The following is a description of a gene set: Mouse Gene Set: KUMAR_TARGETS_OF_MLL_AF9_FUSION studied in species Mus musculus Myeloid leukemia model in mice with germ-line MLL-AF9 fusion knock-in: genes changed in comparison among the leukemic, preleukemic and wild-type animals. Identification of the targets of mixed lineage leukemia (MLL) fusion genes will assist in understanding the biology of MLL fusion gene leukemias and in development of better therapies. Numerous studies have implicated HOXA9 as one of the possible targets of MLL fusion proteins. To determine if HOXA9 was required for leukemia development by MLL fusion genes, we compared the effects of the Mll-AF9 knock-in mutation in mice in the presence or absence of Hoxa9. Both groups of mice showed myeloid expansion at 8 weeks and then developed myeloid leukemia with a similar incidence and time course. The leukemia in the mice lacking Hoxa9 generally displayed a more immature myeloid phenotype than that in the mice that were wild-type for Hoxa9. Gene expression profiling revealed that expression of Mll-AF9 led to overexpression of Hoxa5, Hoxa6, Hoxa7, Hoxa9, and Hoxa10. Thus, genes of the Hox-a cluster are important in defining the phenotype but not the incidence of Mll-AF9 leukemia. These results demonstrate that the Mll-AF9 fusion gene disrupts the expression of several Hox genes, none of which as a single gene is likely to be necessary for development of leukemia. Instead, we propose that the Hox code minimally defined by the Hoxa5-a9 cluster is central to MLL leukemogenesis. from publication Kumar AR, Hudson WA, Chen W, Nishiuchi R, Yao Q, Kersey JH (PMID 14615372), and this is the list of marker genes: Zfp821, Olfm1 (olfactomedin 1), Lct (lactase), Mbnl1, Ctc1, AW112010, Zfp2, Eif3j1, Ear1, Sptlc2, Hdc, Ramp1, Gzma, Klk1b11, Tpi1, Penk, Ptprcap (protein tyrosine phosphatase receptor type C polypeptide-associated protein), Spata6, Cd8a, Spp1, Cdc42ep4 (CDC42 effector protein 4), Txn1, Iglv3, Usp18, Itm2a, Inhba, Rem1, Fasn, Zftraf1, Abhd8, Isg15, Phtf2, Ttc39b, Mettl9, Prg2, Cyp7b1, Rap1a, Ang5, Abcc5, Klrd1, F2rl2, Cd19, Rexo5, Gnb4, Lilrb4b (leukocyte immunoglobulin-like receptor, subfamily B, member 4B), Myo1d, Iglc2, Acads (acyl-Coenzyme A dehydrogenase, short chain), Gjb3, Rps6kb2, Cpsf4 (cleavage and polyadenylation specific factor 4), Ephx1, Ddr1, Gng12, Ptger4, Klk1b2-ps, Pgm1, Il1rn, Hspa4, Enpep, Rusc1, Mid1ip1, Tcstv6a, Fcrla, Pdzk1, Akr1c13, Gas2, Stk39, Klra3, Ncr1, Eomes, Tgif2, Nabp1, Fcna, Rnf220, Atm, Eya2, Lsg1, Reck, Ctsc, Basp1, Cd79a, Arl6ip4, Pde7a, Cyb561, Cebpz, Kmt2a, Polr1b, Hs3st1, Miga2, Lpcat1, Acot9, Ear2, Ica1, Dab2ip, Atxn10, H1f0, Trac, Rbpms, C1qc, Prg3, Chchd10 (coiled-coil-helix-coiled-coil-helix domain containing 10), Bckdha, Hk2, Cxcr5, Eif3e, Fermt3, Satb1, Hivep2, Sox4, Ptch1, Polm, Klra1, Blk, Mr1, Prkca, Zcchc3, Hmgcs1, Klra5, Itk, Igll1, Ms4a2, Tbxas1, Dlat, Cxcr3, Itsn1, Pgrmc2, Ighd, Pdcd6, Atp1b3, Gsdme, Tcstv3, Akap8, Kank3, Scd2, Dmpk, Lhx3, Trbc1, Tert, Sfmbt2, Postn, Aqp9, Dlx6os2, Vpreb1a, Adgrg3, Krtap5-4, Cldn1, Fbp1, F2r, Pax5, Ly6a, Stx18, Hmx3, Hint2, Zfp362 (zinc finger protein 362), Iars2, Angpt1, Fcer2a, Golim4, Klra4, Slc25a53, Tcf7, Cd27, Gusb, Ptp4a3, Taf1b, Alox15, Upp1, Gimap4, Trp53inp2, Prkcq, Ell2, Smagp, Acod1, Ctsb, Zdhhc14, Pdxdc1, Mtdh, Cmbl, Nat8f1, Klk1, Dsp, Gdpd3, Camk2d, Hdac7, Bmal1, Pml, Shd, Ceacam1, Sdc4, Mrps34, Icos (inducible T cell co-stimulator), Il4, 1810037I17Rik, Rsl24d1, Atg7, Pdk1, Clcn3, Serpinb3a, Rnf11, Tm2d2, Klrc1, Dtd1, Tmem30a, Ppic, Fcgr1, Kmt5a, Spic, Rabggtb, Xpo1, Rmc1, Tspan13, Abhd14a, Ormdl3, Klra7, Psip1, Marcks, Hoxa6, Arg2, Wfdc21, Ctsw, Mcpt8, 1700017B05Rik, Hpgd, Plet1, Otud5, Fcer1a, Aldh7a1, Irgm2, Cxxc5, Ebf1, Gsta2, Ugdh, Ms4a1, Gata3, Spata13, Tfb2m, Pls3, Col19a1, St6galnac4, Ctla2b, Slc30a4, Zik1, Scd1, Spib, Prol1, Cln6, Hnrnpa2b1, Anxa1, Armcx2 (NCBI Gene Id 67416), Hoxa10, Psmd9, Ankrd10, Cd55, Tgtp1, Cd8b1, Hoxa9, Blnk, Npepl1 (NCBI Gene Id 97015), Gtpbp2, Ogfod2, Epx, Rsad2, Ddah2, Pccb, Ccr9, Srgap2, Extl3, Dusp9, Ltf, Smo, Klk1b22, Hps1, Meis1, Caprin2, Rbbp6, Klra13-ps, Gapdh, Fkbp9, Eif2s2, Cpa3, Lysmd2, Use1, C1ra, Galnt3, Ralgps2, Cdip1, Idh1, Vta1, Irf4, Fam76b, Perp, Rag1, Pes1, Mef2c, Rab31, Ifit3, Lims1 (LIM and senescent cell antigen-like domains 1), Adar (adenosine deaminase, RNA-specific), Naglu, Cideb, Ctla2a, Hoxa5, Gpc4, Pla2g4a, Cyp11a1, Gabbr1, Cmpk2, Ifit2, Ifnb1, Tcstv1a, Nfe2l2, Gsto1, Cib1, Cd5l, Mgp, F10, Pcbp2, Il7r, Dck, Rhob, Vcam1, Guca2b, Lhpp (phospholysine phosphohistidine inorganic pyrophosphate phosphatase), Vnn3 (vanin 3), Mapk3, Ext2, Traf4, Akt1, Coro2b, Ablim1, Sema6b, Cd83, Myl4, Pla2g7, Ifi204, Ighm, Taf9, Pkp4, Mocos, Ighv1-64, Irf9, Ccng2, Pdlim1, Zap70, Ryr1, Mcoln2, Cox6a2, Ifi27l2a, Trim30a, Epb41l4aos, Txndc17, Gucd1, Ms4a4c, Mag, Nav1, Gpx3, Cyp2d26, Gimap1, Ube2b, Cd2 (CD2 antigen), Cd6, Tmem205, Eln, Plbd1, Cited2, Sh3bgr, Elovl5, Rgs9, Cmtr1, Ifit1, Gpc1, Tnfrsf19, Zfpm1, Pex7, Dntt, Pan2, Nfix, Lef1, Lck, Pou2af1, Il1rl1, Cyp2a4, Cd9, Prdm5, Snhg6, Csnk1a1, Thy1, Lgr5, Dsc1, Frat2, Ltb, Cd5, Vps53, Rps6kc1, Cbx6, 2510039O18Rik, Hoxa7, Cyp2s1, Pramel6, Nsg2, Igf1, Tmem183a, Tmem141, Pfkp, Ly6d, Pim2 (NCBI Gene Id 65950), St6gal1 (NCBI Gene Id 224053), Dnajc3, Ola1, Slc12a2, Cdh5, Sh3glb1, Bpnt2, Slc31a1, F8a, Lgals3bp, Klk1b9, Mmp9, Ccl5, Fyn, Vps41, Cd72 (CD72 antigen), Mrc1, Sit1, Cyrib, Cd3e, Slain1, Kcnab2, Odc1, B4galnt1, Gm11346, Eno1, Glg1 (golgi apparatus protein 1), Rb1